The following is a description of a gene set: Mouse Gene Set: GOMF_ANKYRIN_REPEAT_BINDING Binding to an ankyrin repeat of a protein. Ankyrin repeats are tandemly repeated modules of about 33 amino acids; each repeat folds into a helix-loop-helix structure with a beta-hairpin/loop region projecting out from the helices at a 90-degree angle, and repeats stack to form an L-shaped structure. studied in species Mus musculus, and this is the list of marker genes: Rela, Hif1an, Kif21a (kinesin family member 21A), Tnks1bp1 (tankyrase 1 binding protein 1), Terf1, Oaz3, Shank1